Given this list of marker genes Pdp1, Gstz1, Dld, Dlat, Sirt4, Pdk4, Pdha1, Pdpr, Pdk2, here is a description of the gene set: Reactome Pathway: Regulation of pyruvate dehydrogenase (PDH) complex part of: Regulation of pyruvate metabolism electronically inferred by orthology from the curated human pathway This event has been computationally inferred from an event that has been demonstrated in another species.<p>The inference is based on the homology mapping from PANTHER. Briefly, reactions for which all involved PhysicalEntities (in input, output and catalyst) have a mapped orthologue/paralogue (for complexes at least 75% of components must have a mapping) are inferred to the other species. studied in species Mus musculus